Given this list of marker genes OTX2, KLRD1 (killer cell lectin like receptor D1), ACSBG1, NDST1 (N-deacetylase and N-sulfotransferase 1), SARM1, FAT2, GRAMD1B, TOB2, FBXO41, CARD11, KCNJ10, SCAMP4, PLEKHA6, NMT2, MAP3K3, POLM (NCBI Gene Id 27434), SLC35E4, NCCRP1, C19orf47, DDA1, KCTD15, BAGE2 (NCBI Gene Id 85319), NYX, IL17RA, SGSH, TMEM104, FHIP2B, LYRM4, ZNF597, TOR4A, SH3PXD2A (SH3 and PX domains 2A), TSC1, ARHGEF4, CORO2A, KCNQ5, FHL2, NHP2, ARRB1, ITPR3, SCRT1, GJC1, SEMA4G, ATP11AUN, GNAO1, TMPRSS13, STK40, DNAL1, ELAVL1, TTC28, ZNF83, CALCOCO2, GAS7, TTYH3, ZFTA, CEACAM8, ARMC9, PTK6, GRIK5, TMEM248, CBX6, PPM1L, U2AF1L4, MAVS, PRIMA1, PLA2G4E, C22orf46P, NLGN2, PIP4K2B, DSTYK, WT1, AMACR, PTPN3, RHBDL2, CHRM1, UPB1, KCNG4, KIF1C, NUDT16, C2orf76, PIK3R6, AASS, NRXN2, ECE1, CNBP, SORT1 (NCBI Gene Id 6272), PTPA, MSI2, SLC38A7 (solute carrier family 38 member 7), RNF216, NAA25, APOL6, UBE2Q1 (NCBI Gene Id 84110), LOXL3, ZER1, LRCOL1, ATOH8, GALNT9, SCD, KLC2, SEPTIN8, ELAVL3, FZD4, KCNIP3, IQCJ, NFAM1, TAF8, ATPAF1, CSAG1, RNPEPL1, GSPT1, MYH9, IL23A, TBC1D30, PIK3AP1, TCTA, EXPH5, KCNB1, SRGAP1, RPL28, ATP10B, PPIE, KCNAB2, NGEF (NCBI Gene Id 25791), SLC41A2, PHF12, GATA2, BTBD9, GGA2, GRIK3, TP73, CCDC69, SAA2, BRWD3, MYO15B, AGFG2, SCMH1, NCOA1, ADARB1, ATOSB, SLC17A5, FMNL3, CRTC1, SMPD1, HOXB1, NFIB, FKBP5, SHROOM4, CFAP61, SNAI3, VASH1, CUX2, NAGA, TOM1L2, PRKCSH, STX1B, KCNQ3, P2RX6, TMOD1, MDGA1, HSPB6, here is a description of the gene set: from publication Chen Y, Wang X (PMID 31504780) Genes predicted to be targets of miRBase v22 microRNA hsa-miR-661 in miRDB v6.0 with MirTarget v4 prediction scores > 80 (high confidence targets). Human Gene Set: MIR661 species: Homo sapiens